The following is a description of a gene set: from publication Bucasas KL, Franco LM, Shaw CA, Bray MS, Wells JM, Niño D, Arden N, Quarles JM, Couch RB, Belmont JW (PMID 21357945) Genes positively correlated with titer response index in peripheral blood mononuclear cell in Caucasian male adults (18-40) (low responders) after exposure to Fluarix/Fluvirin, time point 1D. Comment: Signature predictive of titer response index (TRI). Day 1 and day 3 values averaged. Human Gene Set: BUCASAS_PBMC_FLUARIX_FLUVIRIN_CAUCASIAN_MALE_AGE_18_40YO_LOW_RESPONDERS_1DY_POSITIVE_PREDICTIVE_OF_TITER studied in species Homo sapiens BACKGROUND: Annual vaccination is the primary means for preventing influenza. However, great interindividual variability exists in vaccine responses, the cellular events that take place in vivo after vaccination are poorly understood, and appropriate biomarkers for vaccine responsiveness have not been developed. METHODS: We immunized a cohort of healthy male adults with a licensed trivalent influenza vaccine and performed a timed assessment of global gene expression before and after vaccination. We analyzed the relationship between gene expression patterns and the humoral immune response to vaccination. RESULTS: Marked up regulation of expression of genes involved in interferon signaling, positive IL-6 regulation, and antigen processing and presentation, were detected within 24 hours of immunization. The late vaccine response showed a transcriptional pattern suggestive of increased protein biosynthesis and cellular proliferation. Integrative analyses revealed a 494-gene expression signature--including STAT1, CD74, and E2F2--which strongly correlates with the magnitude of the antibody response. High vaccine responder status correlates with increased early expression of interferon signaling and antigen processing and presentation genes. CONCLUSIONS: The results highlight the role of a systems biology approach in understanding the molecular events that take place in vivo after influenza vaccination and in the development of better predictors of vaccine responsiveness., and this is the list of marker genes: ITGB1, PRDX3, PRDX2, E2F2, PTEN